Given this list of marker genes MAP2K2, RAP1A, YWHAB, NGF, CRK, NTRK1, RAPGEF1, MAPK3, KIDINS220, FRS2, MAPK1, CRKL, MAP2K1, BRAF, here is a description of the gene set: part of: Signalling to ERKs Reactome Pathway: Prolonged ERK activation events species: Homo sapiens After NGF binding, activated Trk receptors provide multiple docking sites for adaptor proteins and enzymes. Two docking proteins, the Ankyrin-Rich Membrane Spanning protein (ARMS/Kidins220) and Fibroblast growth factor receptor substrate 2 (Frs2), target signaling molecules in response to NGF stimulation and link receptor activation with the MAP kinase (also called the Extracellular signal-Regulated Kinase cascade, ERK) cascade, an essential process for growth factor-induced cell proliferation and differentiation.<br>A feature of NGF signaling is the sustained activation of the MAPK cascade. This is achieved by the small G protein, Rap1 which binds to and activates B-Raf, an activator of the MAPK cascade. Rap1 is a member of the Ras family of G proteins and like all G proteins, Rap1 is in an inactive state when bound to GDP and is active when bound to GTP. A specific GEF (guanine nucleotide exchange factor) called C3G can activate Rap1 by exchanging GDP for GTP.